The following is a description of a gene set: species: Homo sapiens Human Gene Set: GOMF_ELECTRON_TRANSFER_ACTIVITY A molecular function representing the directed movement of electrons from one molecular entity to another, typically mediated by electron carriers or acceptors, resulting in the transfer of energy and/or the reduction-oxidation (redox) transformation of chemical species. This activity is fundamental to various biological processes, including cellular respiration and photosynthesis, as well as numerous enzymatic reactions involved in metabolic pathways., and this is the list of marker genes: UQCRC1, GPX2 (NCBI Gene Id 2877), COX7A1, NDUFB9, MT-CO1, ETFDH, NDUFB7, NDOR1, NDUFA6, UQCR10, HSD17B6, COX6B1, NDUFB1, ALDH4A1, NDUFC2, NDUFA5, NDUFS1, MT-ND6, MT-CO2, SDHC, GSR, NDUFB5, NDUFA12, MT-CO3, NDUFA10, COX5B, NDUFS3, QDPR, UQCRH, COX7A2L, NDUFV3, FDX2, ALDH2, NDUFA3, COX5A, ETFB, DEGS1, NDUFB4, CYCS, IDH3B, PHGDH (phosphoglycerate dehydrogenase), AKR7A2, GFUS, SURF1, RDH16, CYBA, AKR1C4, NDUFB6, NDUFS8, AKR7A3, NDUFS7, CYP19A1, P4HA2, MT-CYB, NDUFA9, MT-ND2, NDUFS2, NDUFB3, NDUFB10, ME2, NQO2, NDUFA8, ETFA, NCF1, GLRX2, UQCRFS1P1 (ubiquinol-cytochrome c reductase, Rieske iron-sulfur polypeptide 1 pseudogene 1), ME1, AOC2, MT-ND5, MT-ND3, NDUFB2, MT-ND1, NCF2, MTCO2P12, COX4I1, POR, CYBB, MT-ND4L, NDUFV2, AIFM2, HAAO, NDUFS5, ASPH, COX7B, MAOB, SDHD, SDHA, DHRS3, SDHB, NDUFS6, CYP1A2, CIAPIN1, SRD5A1, NOX4, STEAP4, GLDC, ADH5, NDUFA7, NDUFB8 (NCBI Gene Id 4714), NDUFC1, MT-ND4, COX8A, IDO1, FDX1, CYC1, NDUFS4, NDUFV1, DMGDH, NDUFA4, UQCRFS1, COX11 (cytochrome c oxidase copper chaperone COX11), NDUFA1, NDUFA2, UQCR11, AKR1B1 (NCBI Gene Id 231)